Given this list of marker genes PSENEN, NOTCH2NLC, PSEN1, ADAM10, UBA52, PSEN2, CNTN1, NEURL1, MIB1, MDK, NEURL1B, APH1B, NOTCH2, UBC, DLL4, JAG2, JAG1 (NCBI Gene Id 3715), NCSTN, RPS27A, NOTCH2NLA, NOTCH2NLB, DLL1, MIB2, UBB, APH1A, here is a description of the gene set: Human Gene Set: REACTOME_NOTCH2_ACTIVATION_AND_TRANSMISSION_OF_SIGNAL_TO_THE_NUCLEUS studied in species Homo sapiens NOTCH2 Activation and Transmission of Signal to the Nucleus